Given this list of marker genes KCNA5, POTEC, GPC3, TEF, CACYBP, LRRFIP2, FAM149A, ENSA (endosulfine alpha), SENP8, FBXW7, NOL10, MRPS33, POM121, ZNF326, AFF1, TNFSF13B, ENKUR, ANKRD17, PRKCB, PNISR (PNN interacting serine and arginine rich protein), ZNF268, DAXX, KIN, SLMAP, TOMM40L, LHPP, NPAT, SENP6, TRDN, CNBP (NCBI Gene Id 7555), SPRED1, PRKDC, LIPG, ARHGEF33, MFSD6L, TNFRSF11A, SNF8, CPEB4, CCDC43, TAF1L, SESN3, LYSMD4, ZNF618, DBNDD2, KCNA6, LUZP1, NME8, KDM3A, BRINP1, RGS21, TIMM23, RAB31, FKBP9, RAB33B, VIPR1, LSM6, ZNF564, KATNAL1, DNAJB7, AKAP5, PAX1, RAB9A, SP3, NGFR, CDK15, CARNMT1, SH3PXD2A, ABRAXAS2, MDM4, ARFGEF3, DAG1 (dystroglycan 1), GFI1, TMEM35A, TRAK2, TRIM2 (tripartite motif containing 2), SLC35D1, USP34, SORCS3, KRCC1, VCAN, SNAPC4, CDK19, PIN4, ADAMTS15, UBN2, AKT3, ZNF691, THBS1, ALDH8A1 (NCBI Gene Id 64577), RNF111, SMAD1, PRDM13, RBM41, NLGN1, ADAM28, UBASH3A, ARHGEF38, ARPP21, ADRA1D, ADAMTS17, SP1, RANBP3L, PSMG3, NADK2, NRIP3, TENM1, GBP2, RNLS, FCRL2, TRPM8, NASP, SAMD4A, MLLT1, CCNY, RAB3IP (RAB3A interacting protein), RAB26, SPRY4, NABP1, FRAS1, BAHD1, CPPED1, TFE3, DCDC1, FANCG, HOXA9, ZBTB8A, here is a description of the gene set: species: Homo sapiens Human Gene Set: MIR6792_3P Genes predicted to be targets of miRBase v22 microRNA hsa-miR-6792-3p in miRDB v6.0 with MirTarget v4 prediction scores > 80 (high confidence targets). from publication Chen Y, Wang X (PMID 31504780)